The following is a description of a gene set: Any process that results in a change in state or activity of a cell (in terms of movement, secretion, enzyme production, gene expression, etc.) as a result of a cAMP (cyclic AMP, adenosine 3',5'-cyclophosphate) stimulus. studied in species Homo sapiens Human Gene Set: GOBP_CELLULAR_RESPONSE_TO_CAMP, and this is the list of marker genes: ITPR2, IGFBP5, RAPGEF1, WT1, INHBB, WNT10B, ASS1, SCX, CRHBP, PENK, RAPGEF2, AKAP6, RAP1B, RAP1BL, RAP1A, AHR, GATA1, AKAP7, HCN1, PDE2A, ATP5PO, PDE4D, CRTC3, GPD1, ADIPOQ, KDM1A, RAPGEF3, DMTN, AKAP9, TIFAB, CRTC1, AQP8, SLC26A6, SLC8A3, CFTR, HCN4, KCNE1, SRD5A1, SLC5A5 (NCBI Gene Id 6528), INPP5K, SLC26A3, FDX1, AANAT, KCNQ1, FBP1, ZFP36L1, HCN2, PKD2, CRTC2, EEF2K, PIK3CG, STC1, AQP9, AQP1, HCN3, APP, EZR, CPS1